Given this list of marker genes JPH4, OLFM1, IL12A, CSNK2A2, NT5E, STK38L, SAA1, ANTXR1, H2AZ1, PLTP, SERINC2, JAG1, ATP8B4 (ATPase phospholipid transporting 8B4 (putative)), OSM, CAVIN4, TPI1 (NCBI Gene Id 7167), SLC12A3, FCGR2B, CXCL3, IL20RB, ADGRE1, FZD7, SGCE, FNBP1L, MAMDC2, TIAM1, CCR8, NOS2, RTN4RL2, ATP9A, TREM1, GPR18, MYADM, BNC2, PTK6, TMC7 (transmembrane channel like 7), CRCT1, COL6A3, PCBP4 (poly(rC) binding protein 4), NRN1, ATP13A4, CLEC1B, CHCHD10, XYLT2, SUZ12, RAB3C, GCKR, TAGLN2, DENR, TRAF1, B3GALT2, QPCT (NCBI Gene Id 25797), NXNL2, ITGAL, TNFAIP2, CST7, LRIG3, HSPB2, ATP1B1, RIBC1, GPR179, GNAI3, TMEM178A, FYB1, SEMA7A, CDK3, HTR2B, CD200, MMP10, GMCL1, ACP3, EID1, GRAMD2B, IAPP, ECRG4, VTI1A, FKBP14, SPX, CCDC71L, SKIL, PPP1R1B, EMP2, GK, PRR15, BTG1, EGLN3, TGFBI, DUSP1, AKAP3, VCAN, IL1A, CAV1, ASIC3, ZYX, ARL4C, PAX9, GPR176, DDT, SLC7A6 (solute carrier family 7 member 6), TMPRSS11A, SPRY3, IKZF4, PLCD4, IL13RA1, SUSD2, ABCA8, PRDM16-DT, GSTA5, IRAK3, ENOX1, CDC45, AP5Z1, CFAP47, DCSTAMP, NFKBIZ, CLEC4A, SLC20A1, SLC1A2, ZNF446, ZNF143, KRT17, KRT79, RBP4, SCIN, SYNC, SNHG32, REL, ACSL1, ATP5MF, AHRR, SRSF11, SIT1, CACNA2D3, AK1, IL1RAP, ZC3H12A, SLC4A7, ZNF264 (zinc finger protein 264), TAFA3, BTG3, FBXO33, PILRA, MXI1, DLX4, LRFN4, FLRT3, RHOQ, SLA, SV2C, BRDT, IL6, CD72, ADAM19, EPHA4, HEATR6, SPSB1, SLC4A3, MED14, NLRP14, UBE2T, SERPINB12, NCKAP5, ORAI2, RAB32, DVL3, MYLK4, PENK, F13A1, GSPT2, SH3BP4, ROGDI, HMOX1, CARMIL1, BRINP1, KCNF1, DNER, FILIP1L (NCBI Gene Id 11259), FPR1, SLURP1, RAB33A, HAVCR1, SUCO, SNCA, ZBTB3, GRINA, MET, DCN (decorin), CSF3, SOX5, TRIM7, BTC, CH25H, ZFP91, C1QL3, GSK3A, MAGED1, C1S, ABR, CGREF1, POSTN, here is a description of the gene set: studied in species Homo sapiens Gene expression in different thymic stromal cells and subsets thereof was analyzed in 6-12 week old wild type (C57BL/6) and Aire knock-out (mixed background) mice. Thymic stromal cells were purified by sequential enzymatic digestion (collagenase, collagenase/dispase and trypsin) followed by gradient centrifugation and FACS sorting. Sort criteria were as follows: dendritic cells (CD11c+, F4/80 -), macrophages (F4/80+, CD11c-), cTECs (CD45–/lo, CDR1/Ly51+, Ep-CAM+) and mTECs (CD45–/lo, CDR1/Ly51–, Ep-CAM+). mTECs of wild-type and Aire knock-out mice were further subdivided according to CD80 expression levels. For microarray analysis total RNA from thymic stromal cell samples of two independent experiments was pre-amplified and biotinylated by two rounds of cDNA synthesis and in vitro transcription. Fluorescence readings were evaluated by using Microarray Suite 5.0 software. Human Gene Set: GSE2585_CD80_HIGH_VS_LOW_AIRE_KO_MTEC_UP Genes up-regulated in medullary thymic epithelial cells (mTEC) with AIRE knockout: CD80 high versus low. from publication Derbinski J, Gäbler J, Brors B, Tierling S, Jonnakuty S, Hergenhahn M, Peltonen L, Walter J, Kyewski B (PMID 15983066)